Given this list of marker genes CASKIN1, CYP2A6, PAK1, HDLBP, ANP32A, DHH, SYN3, XBP1, PSMB2, TGIF2LX (NCBI Gene Id 90316), ACAT1, PPME1, ST3GAL4, TMEM179, GZMA, GLIPR2, CHADL, NUDT1, KLC3, APOOL, SDF4 (stromal cell derived factor 4), SRRD, ADSL, C19orf47, TBKBP1, SNAPC2 (NCBI Gene Id 6618), MRPL20-AS1, ZFP30, HSD17B10, TAP1, MFAP3, MRS2, TBC1D22A, ATP5F1D, SLC48A1 (NCBI Gene Id 55652), WNT2, COG4, STX6 (NCBI Gene Id 102724791), MCM3, UBA7, TRIP6, EMC3, PSMD14, LAGE3, SETD1A, PFKM, WWP2, HDAC1, LRP8, SEMA4D, GMIP, NUDT5, ADAM33, NUAK2, ANKRD33B, PGLYRP2 (NCBI Gene Id 94295), GEMIN5, GET3, CHPF2, CKAP2L (cytoskeleton associated protein 2 like), SH2D2A, MRPS25, ZNF362, DMRTC2, GDPD5, SUSD3, ZNRF1 (NCBI Gene Id 84937), IL18BP, GZMB, BOLA3, NEU2, COX16, FAM20B, MTHFSD, NPY1R, SLIT2, GTSF1L, ELOA, LELP1, AP1S1, TRIM31, IL12RB1, SH3BP2, TRIM28, PNPO, BOK, PRSS42P, HMBS, EIF4A3, RIPK3, COX6A1, SARS1, PCP2 (Purkinje cell protein 2), NUP62, DHX58, CRYGS, TRAPPC13, IFIT1B, DAPP1, ORAI1, TAMM41, GEMIN8, JUND, P2RY10, CYB5A, P2RX7, TBL3, GABRG3, SRGAP3, MEN1, TAF8, PGPEP1L, UBL4A (ubiquitin like 4A), HEMGN, HLA-DMB, LSM4, AFG2B (AFG2 AAA ATPase homolog B), CEBPD, PPP3CC, MRPL40, INHBE, EFCAB14, TMEM143, MTUS2, CASP14, PATJ, ASCL2, AP1B1, TRAPPC6A, OS9, TAS2R4, IRF4, NFKB1, SP6, ZNF777, MYO1C, NDUFB5, PHGDH, C1orf216, KLHL11, PSAT1, CXXC1, CCDC40, TGFB1, FXR2, MAP1S, FKRP, DUS1L, SMPDL3B, ARID5A, PIDD1, ZNF384, DAAM2, TXNL4A, ERH, POLA2, INO80E, ADAMTS3, A1CF, MYCBPAP, NUMBL, DMKN, VPS11, MRPL49, CKAP2, NFIL3, NANP, C21orf91 (chromosome 21 open reading frame 91), COL26A1, TRAPPC9, ABCB1, SERF2, RPL41, PINX1, OR51B6, HADHA, TIMM17B, PLCD1, GAL3ST1, HTR3A, KIF14, FZD6, TRAF7, ARFGAP3, ENPP3, KCNJ11, SAP18, FKBP8, SORD, ITPR2, M1AP, C8orf33, LTN1, SSBP4, CFAP276, IRF7, TRAPPC5 (trafficking protein particle complex subunit 5), DNPH1, PHF5A, here is a description of the gene set: studied in species Homo sapiens Human Gene Set: GSE32423_IL7_VS_IL7_IL4_MEMORY_CD8_TCELL_DN from publication Ventre E, Brinza L, Schicklin S, Mafille J, Coupet CA, Marçais A, Djebali S, Jubin V, Walzer T, Marvel J (PMID 22942430) Genes down-regulated in comparison of memory CD8 T cells treated with IL7 versus those treated with IL4 and IL7. Effects of IL-4 on CD8 T cells functions are largely unknown. IL-4 induces survival and proliferation of CD8 T cells, but several studies suggest that IL-4 could also affect several functions of CD8 T cells such as cytotoxicity. Our team has shown that IL-4 repress the expression of Ccl5 in vitro. To define more precisely the impact of IL-4 on CD8 T cells, we performed a whole genome expression microarray analysis of naive and memory CD8 T cells cultured in presence or absence of IL-4. This approach allowed us to define the IL4-gene-expression signature on CD8 T cells.